Given this list of marker genes ALMS1, STPG4, IGF1, ANKRD36, FOSL2, RAB27B, LCP2, SLC25A36, DCAF12, UBALD2, PRR11, CRLF3, RAP2B, NCOA2, KLK11, SPRY1, AHCTF1, RBM33, KLHL24, HSPA1A, MYCN, FBXL20, RNF212B, ARHGEF2, RAB40B, DCAF12L2, BSDC1, CNTRL, ERG, HELB, WDR48, CENPU, STAM, ALOX12P2, PPM1K, BCL6, DIS3L2, TEX36, BMP2K, PTAFR, SH2D3C, KCNJ11, CHST2, TRAPPC3L, ZBTB42, RNF24, ZBED6, TAL1, NIPAL3, FDFT1, PRKCQ-AS1, CEBPD, NEURL1B, PRKCQ, MMP16, HDAC9, TAF5, APOC4, DNMT3B (DNA methyltransferase 3 beta), EML6, TRIM8, SSTR5, KDM5A, ACTL8, DUSP6, CCDC69, CSPP1, DCBLD1, HES1, YPEL2, RAB12, TANC1, PNPLA8, PIK3CG (phosphatidylinositol-4,5-bisphosphate 3-kinase catalytic subunit gamma), ST3GAL2, MEF2C, ZNF510, FRAT2, SKIDA1, BTG1, ZMYND8, CDC42EP4, RAB27A, RHEBL1, RIPOR2, SLU7, FRAT1, JMY, HIVEP3, FAM153A, TASL, IRS2, ADCY4, CCDC28A, FAM117B, HBP1, MYB (NCBI Gene Id 4602), CCNG2, C21orf91, SLC26A3, SNX24, TNRC6B, NRXN2, RERE, SZRD1, LRRC36, C1orf167, USP10, MAPRE2, JARID2, FAM106A, KLC3 (NCBI Gene Id 8185), BCL2, MOB2, CASP3, NUP98, MAPK8, MDFIC, LPIN1, RNF44, TRIQK, ZSWIM6, RASSF5 (NCBI Gene Id 83593), TAF4B, LRATD2, KMT2A, NLK, ZFP36L1, NMNAT3 (NCBI Gene Id 349565), AASDH, SKIL, ZNF443, MEIS1, IRAG2, GPRASP2, TERF2IP, LTBP3, NR1D2, ATXN3, HDGFL1, LPAL2, USP47, INO80D (INO80 complex subunit D), MNT, PDCD4, SPOP, CBFA2T3, HECA, SRPK2, PPM1A, PIK3CB, RFWD3, EP400P1, SLC40A1, ACVR2B, TPPP, ST8SIA4, STK4, METTL14, TRIM33, HEYL, SLC38A2, DAB2, PCDHGA8, MYCT1, RNF144B, SIRPD, ATOSA, ATP1A1-AS1, FYB1, FAM117A, ATG2B, TWNK, TMC6, PRSS27, ADRB1, SATB1, TMED8, WNT5B, STON2, CHST12, PNISR, TFCP2L1, TRBV27, MIS18BP1, TBC1D15, JADE2, ZNF609, GFI1B, GJA8, IQSEC2, SKA2, ABI2 (NCBI Gene Id 10152), here is a description of the gene set: from publication Dudziak D, Kamphorst AO, Heidkamp GF, Buchholz VR, Trumpfheller C, Yamazaki S, Cheong C, Liu K, Lee HW, Park CG, Steinman RM, Nussenzweig MC (PMID 17204652) Genes up-regulated in spleen dendritic cells from healthy mice: 33D1+ versus DEC205+ subpopulations. Dendritic cells (DCs) process and present self and foreign antigens to induce tolerance or immunity. In vitro models suggest that induction of immunity is controlled by regulating the presentation of antigen, but little is known about how DCs control antigen presentation in vivo. To examine antigen processing and presentation in vivo we specifically targeted antigens to the two major subsets of DCs using chimeric monoclonal antibodies. Unlike CD8+ DCs that express the cell surface protein CD205, CD8- DCs, which are positive for the 33D1 antigen, are specialized for presentation on MHC class II. This difference in antigen processing is intrinsic to the DC subsets and associated with increased expression of proteins associated with MHC processing. species: Homo sapiens Human Gene Set: GSE6259_33D1_POS_VS_DEC205_POS_SPLENIC_DC_UP